The following is a description of a gene set: studied in species Homo sapiens Human Gene Set: MODULE_132 Genes in the cancer module 132., and this is the list of marker genes: GSTA3, MGST3, GSTA2, GSTP1, GSTM4, GPX3, MGST2, NCF2, NCF1C, GSTA4, GSTM5, SOD1, GSTM2, GSTZ1